Given this list of marker genes Rac1, Ophn1, Picalm, Kcnc3, Ppp3cb, Dgkq, Mff, Arpc3, Pip5k1c, Btbd9, Actb, Sh3gl1, Ap2m1, Dnm1, Rock1, Cxadr, Park7, Bcl2l1, Scamp5, Tor1a, Slc17a7, Prkn, Snx9, Abca13, Snap91, Vamp4, Nlgn1, Dnm1l, Lrrk2, Syt11, Actg1, Syt7, Ppp3cc, here is a description of the gene set: species: Mus musculus Any process that modulates the frequency, rate or extent of synaptic vesicle endocytosis. Mouse Gene Set: GOBP_REGULATION_OF_SYNAPTIC_VESICLE_ENDOCYTOSIS